Given this list of marker genes SLC25A4, IFT74, COQ2, BRAF (B-Raf proto-oncogene, serine/threonine kinase), GRN, COASY, CTLA4, JPH3, ARSA, SPAST, SEMA4D, BBS4, SGCE, GNRH1, DNMT1, PROKR2, FA2H, MSH2, KDM1A, GNA11, TREX1, WDR11, GABRA1, BANK1, SDHA, HIRA, CRH, ATXN10, ESPN (espin), PRKACA, FCGR3B, CHEK2, CFTR, GDAP2, BLK, HMOX1, MLH1, IFNG, MEN1, PRKCG, POLG2, PSAP, FLT4, DEPDC5, AP2S1, CHCHD2, MT-TW, STX16, TET3, POLG, FGF14, TBX1, CHD8 (NCBI Gene Id 64329), OPTN, CDH23, TWNK, MAPT, GPRC5B, FMR1, FKBP5, SLC26A9, MT-TT, ARVCF, KRAS, SCAPER, CLCN4, OCRL, AR, GCH1, ATP7B, CRKL, ITGAM, SLC6A4, MKS1, CHRNA4, ADH1C, CACNA1H, IFT172, MEFV, VPS37D, XPR1, PLP1, ATXN3, C9orf72, ABCB4, MIF, PON1, NEFH, FUS, MST1, MAPK1, UQCRC1, DNAJC5, GLA, NEK1, MKKS, AARS2, CLCA4, USH1C, MT-ND6, NODAL, GP1BB, KISS1R, VPS35, PPP2R2B, MAMLD1, PANK2 (pantothenate kinase 2), CEP290, EIF4G1, CEP85L, ATM, FCGR2B, GABRB3, MT-TQ, SLC7A6OS, NAA60, C19orf12, CACNA1G, TNFSF4, TTC8 (NCBI Gene Id 123016), GNRHR, C4B, MYO7A, GIGYF2, BUD23 (BUD23 rRNA methyltransferase and ribosome maturation factor), ZNF365, CPOX, COL7A1, BBIP1, GLE1, PTRHD1, STUB1, HTRA2, MMP1, BRCA2, PDE11A, PRNP, VPS13A, PLCH1, CEACAM6, DUSP6, PON2, ALAD, TLR7, WHRN, PPT1, CDON, CFAP418, GRIN2A, AFG3L2, PAH, ALDH4A1, DISP1, CBS, GPR35, FIG4, BBS10, CR2, POLE, ATRX, DNAJC6, NCF1 (neutrophil cytosolic factor 1), SCLT1, NR3C1, CLIP2, CDKN1A, PRPH, HLA-DRB1, CDKN2C, BBS9, FGFR1, JRK, GCLC, CHCHD10, TRANK1, ATP9A, TNIP1, CLN6, HMBS, SQSTM1, PRKAR1A (NCBI Gene Id 5573), HARS1, SLC2A1, PPARGC1A, IGHG1, PDGFRB, MECP2 (NCBI Gene Id 8274), SYNJ1, MT-TL1 (NCBI Gene Id 4567), IL10, HLA-B, DNA2, PLA2G6, NHLRC1, PINK1, IRF5, P2RY11, BBS1, SPR, IMPDH2, UFD1 (ubiquitin recognition factor in ER associated degradation 1), LZTFL1, KCTD17, TBK1, MPV17, CDKN1B, ATXN2, BBS5, TP53, TTC19, GALT, BBS2, STAG2, CSF1R, VCP, EDNRA, USP48, GPR101, CASR, GTF2I, ABCA7, HTT, MSTO1, UNC13A, BMPR1A, GLT8D1, KCNJ2, CCNF, BCS1L, TGIF1, SLC20A2 (solute carrier family 20 member 2), NOTCH3, KIAA0319L, PCDH15, TBC1D7, GNAS, TOR1A, JMJD1C, PDGFB, TGFB1, CIB2, TMEM106B, FMO3 (NCBI Gene Id 2328), LRRK2, PROK2, PMS1, CEP78, PRKN, MT-TL2, SIX3, NR1H4, PER2, POLD1, SOD1, TRIM32 (tripartite motif containing 32), IRAK1, UCHL1, PTPN22, RPS6KA3, CABP4, PON3, HNRNPA1, SHH, AOPEP, GAS1, GBA1, SDCCAG8, EPCAM, WDPCP, ATP8B1, ABCB7, USH2A, KCNT1, CFAP410, MT-TH, ZIC2, JAZF1, CYP27A1, DAO, CEACAM3, ADA2, DLL1, RELN, NR4A2, CLRN1, NHLH2, SMC1A, CTSH, MATR3, GSTM3, MT-TF, TSC2 (NCBI Gene Id 7249), MT-CO2, ADGRV1, STX1A, SPRY4, CDKN2B, SLC6A14, HS6ST1, ARSG, SCARB2, DCTN4, TPH2 (tryptophan hydroxylase 2), DRD2, DCTN1, EPM2A, CARS1, ATP13A2, IFT27, ANXA11, PTS, ZFX, ETS1, PARK7, SEC24C, SPP1, TGFBR2, ABCB11, ARMC5, FOXH1 (forkhead box H1), EIF4H, CISD2, HCRT, HFE, COMT, PSEN1, SNCA, SEMA4A, GLI2 (NCBI Gene Id 50806), KMT2B (lysine methyltransferase 2B), ATXN8OS, CRIPTO (cripto, EGF-CFC family member), SLC11A1, MT-ND4, ATP2A2, CTCF, CHRNB2, SERPINA1, CTSF, DNAJC13, PDZD7, VAPB, LGI1, STAT4, PXK, ATP1A3, WARS2, TMEM270, TSHB, TK2, C4A, RRM2B, MT-CO1, ARL6, TAC3, FGF17, SLC9A3, RPS20, RREB1, GTF2IRD2, TNFAIP3, EHMT1, MT-ND5, PODXL, BBS12, PDCD1, MT-ND1, CHD7, SPTBN1, TCF4, MT-TN, TREM2, ERBB4, STIL, RFC2, PFN1, LIMK1, IRF4, OTC (ornithine transcarbamylase), PER3, TBP, HTR2A, USH1G, MOG, GTF2IRD1, TAF15, CACNA1I, TARDBP, CHMP2B, THOC2, FGF8, KISS1, SRPX2, DGUOK, ANG, PIK3CA, MAN2B1, MT-TS2, AMACR, MSH6, SLC2A3, GSN, UBE2L3, TACR3, MUTYH, ENSG00000288330, USP8, UBQLN2, KCNN4, IDUA, WFS1, SMPD1, AP1G1, DNAJC30, NPHP1, TRHR, PTCH1, TSC1, AIP, FXN, NSMF, BCR, PMS2, BAZ1B, TDO2, FKBP6, PTPA, ELN, P4HA2, METTL27, HLA-DQB1, XK, GABRG2 (NCBI Gene Id 2566), MT-CO3, TBL2, CHRNA2, ITPR1, DNASE1, HLA-DQA1, VPS13C, CEP19, BBS7, SNCAIP, here is a description of the gene set: Frequently experiencing feelings of being down, miserable, and/or hopeless; struggling to recover from these moods; having a pessimistic outlook on the future; feeling a pervasive sense of shame; having a low self-worth; experiencing thoughts of suicide and engaging in suicidal behavior. Depression Human Gene Set: HP_DEPRESSION species: Homo sapiens